Given this list of marker genes Dcbld2, Abcc6, Sart3, Ywhaz, Ugt3a1, Tmem255a, Mybl1, Cwc27, Srpx2, Clgn, Stox2, Mrpl17, Tctn3, Tex56, Has3, Gm4884 (predicted gene 4884), Phlpp1, Ep300, Nrxn1, Lalba, Brk1, Adi1, Slc30a1, Gabra1, Spint3, Slc24a2, Slc25a10, Usp29, Phactr2, Ptov1, Hsdl1, Fbxo32, G3bp2, Ppp2r2d, Vbp1, Gja1, Sh3pxd2a, Inpp4b, Ncf2, Rhox4c, Zfp507 (zinc finger protein 507), Amigo1, Ubfd1, Slc10a7, Nrl, Nr1d2, Ano7, Macrod2, Eif4a1, Mrc2, Rgs17, Uxt, Slc26a5, Otub2, Itih6, Rhox4e (NCBI Gene Id 194856), Zmpste24, Rhox4b, Ppp2r2b, Slc25a21, Rnf111, Chi3l1, Rhox4a, Rpap2, Clec1a, Rgs2, Eny2, Foxo3, Gpc5, Klk9, Hccs, Slc25a31, Zdhhc8, Dnajb4, Igf2bp1, Angptl7, Tmem167, Plxdc2, Pdzrn4, Fam81a, Rhox4d, Man1a2, Mgat2, Prrg3, Tab1, Ubtd2, Vps39, Asah2, Rpgrip1l, Mfap3l, Psors1c2, Chadl, Pcdh19, Styk1, Bpnt2, Ppp1cb, Magi1, Thsd7a, here is a description of the gene set: Genes predicted to be targets of miRBase v22 microRNA mmu_miR_1258_3p in miRDB v6.0 with MirTarget v4 prediction scores > 80 (high confidence targets). Mouse Gene Set: MIR_1258_3P from publication Chen Y, Wang X (PMID 31504780) species: Mus musculus